Given this list of marker genes AKT1, MAPK1, TGFB1, CCNB1, IL4, STAT6, SOCS5, MAPK3, COL1A1, IL19, CCL11, IL20RA, NFKB1 (NCBI Gene Id 4790), SOCS1, ACTA2, IL4R, MMP1, IL20RB, MUC5AC, CXCR4, TNFRSF1A, JAK1, MAPK8, TNF, STAT1, RAC1, MAPK14, STAT3, here is a description of the gene set: IL19 signaling species: Homo sapiens Human Gene Set: WP_IL19_SIGNALING